The following is a description of a gene set: A type of focal-onset seizure characterized by a motor sign as its initial semiological manifestation. Focal motor seizure studied in species Homo sapiens Human Gene Set: HP_FOCAL_MOTOR_SEIZURE, and this is the list of marker genes: EN1, NR4A2, SRPX2, KCNQ2, SDHD, NGLY1, ARX, CACNA2D1, ERMARD, CAMTA1, SIK1, STXBP1, SCN1B, GNAO1, DMXL2, MICAL1, SCN1A, SCN2A, GRIN1, KCTD7, WWOX, GNB1, TRIM8, CASK, CABP4, MTOR, SATB1, SMS, PLCB1, CHRNA4, PIK3CA, PYCR2 (pyrroline-5-carboxylate reductase 2), ATP1A3, TBC1D24, MRAP, SLC32A1, PRRT2, GABRG2, GRM7, CHRNB2, KCNT1, DEPDC5, SMARCAL1, SCN9A, PNKP, NEUROD2, CHRNA2, DPYD, SNORD118, KCNQ3, KCNH5, ATXN10, SLC1A3, LGI1, SDHB, KCNA1 (potassium voltage-gated channel subfamily A member 1), KCNK4, NDUFA2, POU4F1, EXTL3, DPAGT1, SLC1A2, HACE1, POLG, PURA, PCDH12, PLPBP, YWHAG, PPP3CA, CDKL5, GABRA1, PCDH19, PIGQ, ADAM22, ATP1A2, SDHA, RELN, PEX3, FRRS1L, SLC35A3, BTD, CACNA1A, SLC12A5, WDR45B, FZR1, GLUL, NDUFAF6, KANSL1 (KAT8 regulatory NSL complex subunit 1), PIGA, COQ4, ALDH7A1, LAMC3, PAFAH1B1, SCN8A, GABBR2, FAR1 (fatty acyl-CoA reductase 1), PIGP, AP3D1 (NCBI Gene Id 8943, adaptor related protein complex 3 subunit delta 1), GRIN2A, PACS2, OTUD7A, CUX2, SDHAF1, PTPN23, CRH, CACNA1D, SLC25A22, ST3GAL3, CLCN4, GLYCTK, UFSP2, GRIA3, AKT3